Given this list of marker genes PHTF2, ADAM23, TLR2, HEXB, PBXIP1, FTL, CLIC1, ACSL4, EIF4G2, UBP1, TFB2M, CERS5, STMN1, PRSS16, PLPP1, MGST1, NSDHL, TMEM131L, SLF2, PPBP, CSF2RB, TEX261, ACRBP, APBB2, ACSS2 (acyl-CoA synthetase short chain family member 2), AGTPBP1, CXCL3, LAMTOR3, TBC1D24, ZFP36L1, ABHD17C, MRPS14, USP36, KIF3C, LAS1L, UBE2E2, XPR1, IP6K1, PNO1, EMB, RPA1, PLPP2, MAPK10 (NCBI Gene Id 5602), NSF, LMAN2, POLR1A (NCBI Gene Id 90784), RHOT2, SPRY1, LPGAT1, C11orf24, DEPDC7, WDR12, PRRG2, PRMT3, AOAH, GNAQ, PCBP2, CD48, IPO9, CD302, QNG1, DDT, PUM3, PPP5C, TSNAX, XYLT2, SKP1, SRD5A3, AKR1B15, SYS1, LRPPRC, TNF, SEZ6L2, ACADM, CDR2, SEPHS2, MRPL12 (mitochondrial ribosomal protein L12), ENO3, RPL28, COA6, PLAUR, UQCRC1, VPS35, GPCPD1, SIRT4, SS18, VPS39 (VPS39 subunit of HOPS complex), NME6, UBD, HDGF, CXCL6, XPO7, DNM1, PC, REXO2, SIRPA, VASP, SEC11A, FECH, SLCO5A1, NDEL1, PRMT2, YAF2, POLR3G (NCBI Gene Id 10622), PIK3C2A, PLEKHJ1 (NCBI Gene Id 55111), ZNF639, TMEM141, RAP2A (NCBI Gene Id 5911), CDC37, ZNF330 (zinc finger protein 330), SLC66A1, ELOVL1, RPS3, ARHGEF1 (Rho guanine nucleotide exchange factor 1), EGR1, SDHA, RPIA, LIMD1, ATG5, CNOT9, PPARG, SNF8, MCUB, MPHOSPH10, SLC20A1 (solute carrier family 20 member 1), GLMP, MPND, DESI2, CFP, RABGAP1L, CSGALNACT2, SPCS3, RPP14, GNL2, RRP8, CCT8, KDM2B, OAT, FAM149B1, PPT2, MVD, SNX12, CLIP1, PACS1, TIMM10B, NOP14, ARRB1, TP53RK, GORASP2, HECTD3, FGD4, DCTN5, JAGN1, ZNF704, HES6, NPM1, GRIP1, PNPO, MIA3, DHRS7B, KRR1, TSPAN14, PPP1R14B, TUBG1, SFT2D1, EPS15, ACTR1A (actin related protein 1A), TIMM8A, EIF3A, SGK1, UBE2A, NR2C2AP, PRPF39, TMEM14C (NCBI Gene Id 51522), METTL3, SSR2, UTP4, PPP2R5C, CDKN2B, HNRNPDL, BDH1, FBXO22, INPP5A, SASH1, GPR155, AIMP1 (NCBI Gene Id 9255), HTATIP2, PTCD2, BRIX1, ANXA3, CLEC6A, SESN2, CDC42SE2, NRG4, BST1, VPS29, NCF2, MOB3B, here is a description of the gene set: mouse primary BMDCs were stimulated with tlr ligands and gene expression changes were profiled on Affymetrix arrays from publication Amit I, Garber M, Chevrier N, Leite AP, Donner Y, Eisenhaure T, Guttman M, Grenier JK, Li W, Zuk O, Schubert LA, Birditt B, Shay T, Goren A, Zhang X, Smith Z, Deering R, McDonald RC, Cabili M, Bernstein BE, Rinn JL, Meissner A, Root DE, Hacohen N, Regev A (PMID 19729616) Human Gene Set: GSE17721_LPS_VS_GARDIQUIMOD_6H_BMDC_DN Genes down-regulated in comparison of dendritic cells (DC) stimulated with LPS (TLR4 agonist) at 6 h versus DC cells stimulated with Gardiquimod (TLR7 agonist) at 6 h. species: Homo sapiens